The following is a description of a gene set: Genes down-regulated in comparison of polysome bound (translated) mRNA versus total mRNA in dendritic cells. from publication Ceppi M, Clavarino G, Gatti E, Schmidt EK, de Gassart A, Blankenship D, Ogola G, Banchereau J, Chaussabel D, Pierre P (PMID 19943945) Dendritic cells (DCs) are the sentinels of the mammalian immune system and they undergo a complex maturation process mediated by activation upon pathogen detection. Recent studies described the analysis of activated DCs by transcriptional profiling, but translation regulation was never taken in account. Therefore, the nature of the mRNAs being translated at various stages of DC activation was determined with the help of translational profiling, which is the sucrose gradient fractionation of polysomal-bound mRNAs combined to microarrays analysis. Total and polysomal-bound mRNA populations were compared in immature (0h) and LPS-stimulated (4h and 16h) human monocyte-derived DCs with the help of Affymetrix microarrays. Biostatistical analysis indicated that 296 mRNA molecules are translationally regulated during DC-activation. The most abundant biological process among the regulated mRNAs was protein biosynthesis, indicating the existence of a negative feedback loop regulating translation. Interestingly, a cluster of 17 ribosomal proteins were part of the regulated mRNAs, indicating that translation may be fine-tuned by particular components of the translational machinery. Our observations highlight the importance of translation regulation during the immune response, and may favour the identification of novel gene clusters or protein networks relevant for immunity. Our study also provides information on the possible absence of correlation between gene expression and real protein production in DCs. studied in species Homo sapiens Human Gene Set: GSE14000_TRANSLATED_RNA_VS_MRNA_DC_DN, and this is the list of marker genes: RPLP1, FOXB1, RPL12, PIGY, CNOT9, ORAI2, AP5S1, RPS5, PRMT2, NICOL1, OST4, CHST8, RPL19, NDUFAF3, RXYLT1, ATP6V1C2, ARPC1A, LST1, CELA1, ADAP2 (NCBI Gene Id 55803), GDE1, DNAH17, IDS, TAL2, SLC29A4, ORMDL1, FAM200B, KY, TMEM222, C17orf49, KRBA2, RPS6, TMEM141, CPSF4, BID, JTB, RPS10P5, UROS, RPL23A, DAP, SSNA1, DNAAF8, TRAF7, RPL11, PTPN18, H1-9P, BCL7B, RPS15A, ZNF688, CD99, ZFYVE21, POP7, RPS18, RPS25, RPL4, SNX3, GNG5 (G protein subunit gamma 5), SLC25A51, MAN1B1-DT, LSM10, DNAJC22, BCL7C, ZDHHC4, MAPK11, GUK1, CDC42EP5, ARL5A, SSU72, HIKESHI, GPR12, PDIA2, TYW3, DEAF1, IGDCC3, TLCD3B, ARL2BP, PLPPR2, SLC25A6, C2orf68, ZNF32, SURF1, ST6GAL2, RPL23, CTDNEP1, RPL36, EPHB4, GPX4, PTPRO, RPL35, ENSG00000289161, NOP53, SLC9C2, RPL26, SMIM12, DUSP23, PDCD5, GTPBP6, SDF2L1, LSM12, RPL13P5, EEF1B2 (eukaryotic translation elongation factor 1 beta 2), KCNJ10, EEF1D, RWDD1, SPG21, TMIGD2, DUSP3, LZIC, ACSM3, ZNF511, TMEM250, BRI3, EPRS1, LITATS1, HOXB1, IGBP1, RPL8, SLC4A5, RPL18, DHRS12, RPUSD1, RPSA, RPS11, SMIM20, RPL10, STX10, FOLR3, TMEM42, RPL10L (ribosomal protein L10 like), TP53TG1 (NCBI Gene Id 11257), RPL32, YBX1, YPEL3, KDELR2, RPL21, SLC35D2, RPS10, C7orf50, RPL30, METTL26, PARP6, UQCC3, COX20, ADAP1, CRTAP, RPLP2, PTP4A2, B4GALT7, CISD3, VHL, LAMTOR1, BATF3, RPL13A, RPL39L, PLPBP, GTF3A, TMEM134, EIF4B, SYS1, TRAPPC3, HPCA, ANKRD39, ENTREP3, RACK1, PTCHD3P1, RPS3, TBPL1, A1BG, CCNQ, SIGLEC17P, RNF7 (NCBI Gene Id 9616), IMPDH2, RPS14 (ribosomal protein S14), MED14OS, IGLON5, TMEM147, NDUFB10, SERP1, TMEM219 (transmembrane protein 219), RPLP0, HACD4, PROSER3, RPS12, ATP5F1E, NAXE, RPL17, OR3A3, CIDEB, IFT20, RPS13, PABPC1, ZNF91, NAA38, PABPC4, EIF3L